The following is a description of a gene set: Any process that decreases the rate, frequency, or extent of protein serine/threonine kinase activity. Mouse Gene Set: GOBP_NEGATIVE_REGULATION_OF_PROTEIN_SERINE_THREONINE_KINASE_ACTIVITY species: Mus musculus, and this is the list of marker genes: Cdkn1b, Lyn, Ptprj, Sirt1, Spry4, Kat2b, Adipoq (NCBI Gene Id 11450), Cdkn2a, Rgs2, Smpd1, Dab2ip, Cdk5rap1, Fem1a, Wee2, Chordc1, Rgs14, Stk38, Dnaja1, Aida, Dusp7, Sfrp2, Dusp1, Rasip1, Hipk3, Plk1, Blvra, Ptpn22, Hyal2, Inpp5k, Pdcd4 (programmed cell death 4), Tfap4 (NCBI Gene Id 83383), Nup62, Tnfaip3 (tumor necrosis factor, alpha-induced protein 3), Prkch, Nolc1 (NCBI Gene Id 70769), Casp3, Ptpn6, Cd300a, Uchl1, Agt, Cdk5rap3, Slc8a1, Myocd, Men1 (multiple endocrine neoplasia 1), Ifng (NCBI Gene Id 15978), Apc, Irak3, Hmgcr, Cav1, Lats1, Pparg, Dusp19, Pycard, Spry2, Cblc, Dusp10, Mapk8ip1, Gstp-ps, Inca1, Gstp2, Nppa, Dtnbp1, Prkcd, Pkib, Apoe (apolipoprotein E), Nf1, Cdkn2c, Pten, Gadd45a, Macroh2a1, Cav3, Gstp1, Heg1, Cdkn1a, Paqr3 (progestin and adipoQ receptor family member III), Sfrp1, Spry1 (NCBI Gene Id 24063), Nr2f2, Lats2, Pkia, Hexim2, Il1b, Slc8a3, Hhex, Gstp3, Bmp2, Gba1, Ptpn1, Fbxo7, Sfrp5, Abl1, Lrp6